The following is a description of a gene set: studied in species Homo sapiens The directed movement of substances from endosomes to vacuoles by a pathway in which molecules are sorted into multivesicular bodies, which then fuse with the vacuole. Human Gene Set: GOBP_LATE_ENDOSOME_TO_VACUOLE_TRANSPORT_VIA_MULTIVESICULAR_BODY_SORTING_PATHWAY, and this is the list of marker genes: VPS37A, LEPROT, TMEM50B, CHMP6 (NCBI Gene Id 79643), LEPROTL1, TMEM50A, CHMP4A, PTPN23, MVB12A, STAM, MVB12B, CHMP4B (charged multivesicular body protein 4B), CHMP4BP1 (charged multivesicular body protein 4B pseudogene 1), VPS28, CHMP4C, VPS37C, VPS25, CHMP7, SNF8, VPS37D, VTA1, CHMP5, UBAP1, TSG101, STAM2, HGS, VPS36, VPS37B